The following is a description of a gene set: Human Gene Set: HP_LIMB_TREMOR Limb tremor species: Homo sapiens, and this is the list of marker genes: LMNB1, ITPR1, CACNA1G, CDC42BPB (NCBI Gene Id 9578), GRIA3, CLN5, SNRPN, ANO3, PGAP1, MPZ, SLC12A6, PEX16, CARS2, PLA2G6, CIZ1 (NCBI Gene Id 25792), TUBB4A, DDC, TSPOAP1, PMP22, ITPA, UBE3A, COL6A3